The following is a description of a gene set: species: Mus musculus part of: Selenoamino acid metabolism electronically inferred by orthology from the curated human pathway Reactome Pathway: Selenocysteine synthesis This event has been computationally inferred from an event that has been demonstrated in another species.<p>The inference is based on the homology mapping from PANTHER. Briefly, reactions for which all involved PhysicalEntities (in input, output and catalyst) have a mapped orthologue/paralogue (for complexes at least 75% of components must have a mapping) are inferred to the other species., and this is the list of marker genes: Sephs2